The following is a description of a gene set: Mouse Gene Set: GOBP_REGULATION_OF_CALCIUM_ION_TRANSMEMBRANE_TRANSPORTER_ACTIVITY species: Mus musculus Any process that modulates the frequency, rate or extent of calcium ion transmembrane transporter activity., and this is the list of marker genes: Sln, Casq1, Gsto1, Stac3, Cracr2a, Calm3, Atp2a1, Gnb5, Hpca, Drd4, Smim6, Hap1, Slc9a1, Asph, Stim2, Jsrp1 (junctional sarcoplasmic reticulum protein 1), Fmr1, Gpr35, Calm2, Sri, Tlr9, Ank2, 1810037I17Rik, Nipsnap2, Strit1, Stac, Ehd3, Drd2, Mrln (myoregulin), Gstm7, Pkd2, Dmd, Htt, Stac2, Cbarp, Ubqln1, Calm1, Cacnb4, Jph3, Cacnb3, Pln, Sumo1, Casq2, Fkbp1a, Myo5a, Stim1, Jph2, Vmp1, Fkbp1b, Ahnak, Stimate, Fgf14, Dysf, Selenon, Cacna1f, Hrc, Cav3, Cacnb2, Hspa2, Zfas1, Plcg2